The following is a description of a gene set: studied in species Mus musculus Mouse Gene Set: GOBP_PROTEIN_TRANSPORT The directed movement of proteins into, out of or within a cell, or between cells, by means of some agent such as a transporter or pore., and this is the list of marker genes: Stx1a, Cplx1, Chmp6, Pom121l2, Grb2, Clstn3, Igtp, Hspa9, Os9, Gabarap, Ptpn14, Dgkd, Prkcz, Tmed2, Psap, Timm23, Egfr, Anp32b, Ghsr, Kif1a, Il1b (interleukin 1 beta), Ice1, Nlgn2 (NCBI Gene Id 216856), Ap4b1, Zdhhc17, Ankrd1, Rptor, Htt, Psen1, Washc2, Hsp90b1, Mir130a, Rab32, Ap5b1, Ptpn5, Traf3ip2, Erp29, Tfr2, Camk2n1, Lyst, Nutf2-ps2, Pttg1ip2, Arl6, Kpna6, Ang6, Stk4, Atp13a1, Ykt6, Ube2q1, Arrdc2 (arrestin domain containing 2), Snx21, Vti1b, Selenot, Cd74, Mapk8ip3, Akt1, Ramp1, Dnajc19, Tmem132a, Senp2, Tomm7, Cry2, Rab10, Nr1h4 (NCBI Gene Id 20186), Nup50l, Bcap29, Lin7b (lin-7 homolog B, crumbs cell polarity complex component), Sirt1, Nup42, Angpt1, Clu, Chmp4c, Rab11fip1, Pgrmc1, H2-DMa, Apba3, Rabif, Vps13d (NCBI Gene Id 97180), Snx20, Kcnj11, Pex1, Cd36, Mup4, Calcrl, Cask, Unc93b1 (NCBI Gene Id 54445), Srp54a, Rangap1, Ndp, Map1a, Sytl3, Tek, Stx18, Tmed6, Tomt, Vps37c, Tbc1d17, Tmem97, Fhip1b, Nacad (NCBI Gene Id 319576), Cnih4, Bcs1l, Hspa5, Ipo5, Tecpr2, Adam9, Arf2, Lypla1, Pdcd6ip, Ptpn11, Pttg1ip, Aup1, Dynll1, Arl8a, Neo1, Guk1, Pex10, Ccn3, Atg4a, Ptpmt1, Neurl1b, Gper1, Selenok, Tmem167, Edem1, Vps35, Mpc2, Drd3, Elmod3 (ELMO/CED-12 domain containing 3), Zbed6, Myh10, Jup, Nsg1, Lrrc8a, Hps6, Il12a, Apobec1, Zfand1, Sec23b, Dyrk1a, Zc3h12a, Bcl3, Adcyap1, Washc1, Camk1, Lcp1, Chrm3, Pex16, Irgm2, Ier3ip1, Nkx6-1, Ergic3, Parp11, Cd200, Timm44, Hyal2 (hyaluronoglucosaminidase 2), Stradb, Ffar1, Il6, Nmd3, Gpr39, Atg16l2, Hikeshi, Rab11fip2, Dynlt1c, Picalm, Apoc2l, Stx3, Sirt4, Doc2b, Hm629797, Dmap1, Cav1, Grpel2, Ranbp6, Dennd10, Fras1, Tlr4, Mdm2, Apob, Cmtm6, Cartpt, Spire1, Use1 (NCBI Gene Id 76848), Csk, Cog8, Rab9, Vcp, Vldlr, Rab3c, Pik3r2, Chmp1b2, Golga2, Rab2b (NCBI Gene Id 78858), Wls, Eps15, Bbs2, Il1a, Flna (filamin, alpha), Ffar3, Faf2, Brca1, Cog3, Ect2, Tm9sf4, Rep15, Gosr2, Rfx3, Vps50, Dgat1, Uso1, Kcnq2, Pik3c3, Romo1, Rapgef3, Vps52, Snx25, Trpm4, Ildr2 (immunoglobulin-like domain containing receptor 2), Herpud1, Aacs, Pitpnm1 (phosphatidylinositol transfer protein, membrane-associated 1), Btf3, Timm13 (NCBI Gene Id 52584), Snap23, Trpm2, Nploc4, Fcgr4, Ang, Rab3il1, Mdfic, Foxa2, Synrg, Sort1, Elavl1, Atp6ap1, Ppard, Copz1, Map4k4 (NCBI Gene Id 98646), Hcfc1, Rabgap1l, Ccdc93, Rhbdf2, Exoc6, Uts2 (urotensin 2), Apbb1, Ctdspl2, Prepl, Arf6, Efcab7, Camk2a, Tardbp, Cplx3, Cog1, Fam3a, Ripor1, Fam3b, Exoc1, Cd3g, Myh9, Snx9, Agtr2, Pex7, Rab27a, Pex14, Ddx5, Gopc, Snx7, Snx4, Rbsn, Dmbt1, Pde4c, Tgfb3, Sidt2, Gdi2, Cd38, Lrrk2, Kpna7, Dennd1a, Stat3, Vps37a, Ppm1a, Vps41, Dnajc1, Timm17b, Plekhf2, Marcks (myristoylated alanine rich protein kinase C substrate), Ift56, Ing1, Pkig, Scarb2, Glp1r, Afm, Egr2, Cftr, Kcnq3, Itpr1, Mup5, Srcin1, Phaf1 (NCBI Gene Id 338512), Lamp2, Vps18, Uhmk1, Sorcs2, Anxa7, Stx11 (NCBI Gene Id 74732), Pde8b (NCBI Gene Id 77611), Snx10, Pde1c, Tiam1, Snx30, Efna5, Klhl20, Tomm70a, Vipas39, Slc30a8, Kif20b, Ranbp3, Snord33, Rab7b, Rph3al, Rpain, Kif3a, Ang4, Pick1, Idh2, Casr, B4galnt2, Tomm20, Pex6, Notch1, Arl4d, Ang5, Tlk1, Kpna2, Nup62, Mtx2, Hnrnpm, Fchsd2, Pcsk1, Fga, Aftph, Agtr1a, Sec61a1, Hook2, Stxbp2, Pex19, Nxt1 (NTF2-related export protein 1), Stx17, Gle1, Tfap2b, Prickle1, Prkcq, Nup85, Derl1, Grin2a, Rtn2, Bloc1s6, Kpna4, Arhgef5, Itsn1, Frat1, Bet1l, Bmpr1a, Glul, Chchd4 (NCBI Gene Id 72170), Exoc5, Ankle1, Mtx1, Septin8, Duoxa2, Bbs7, Gpr27, Cltb, Rph3a, Scamp3 (NCBI Gene Id 24045), Heatr3, Ahi1, Stim1, Ppp3cb, Acsl4 (acyl-CoA synthetase long-chain family member 4), Snord34, Rack1, Fndc1, Pdcd5, Cltrn (NCBI Gene Id 80522), Isl1, Mylk, Sergef, Cep131, Rab19, Tom1l1, Ipo4, Prkaca, Gipr, Rilpl1, Zg16, Vps4b, Ankrd27, Stx19, Timm8a2, Rab7, Trim3, Afg2b, Vps36, Ccl5, Rhbdd3, Cog5, Bmpr2, Nup155, Snap91, Cttn, Frmpd1, Nup50, Pgap1, Ap1s2, Rab31, Hnf1b, Vps13c, Rab22a, Pdx1, Rilp, Ap4m1, Ppt1, Hpse, Peg12, Dynlt1a, Six2, Pik3r4, Atg14, Gnaz, Tnpo3, Pex5, Rest, Xbp1, Vamp2, Crhr2, Ramp2, Kpna2rt, Hmgn3, Cd24a, Ehd1, Selenbp2, Gpihbp1, Becn1, Tango2, Ranbp3l, Snx17, Dynlt1b, Nup160, Hadh (NCBI Gene Id 99932), Tram1, Rab5c, Unc119, Stx5a, Eipr1, Plk3, App, C2cd2l (C2 calcium-dependent domain containing 2-like), Snx27 (sorting nexin family member 27), Pkd1, Tmed4, Sec61g, C1qtnf5, Stxbp3, Trarg1, Rims1, Ap1g2, Sacm1l, Osbp, Nolc1, Sel1l, Rftn1, Mup3, Cdkn2a, Pde3b, Raf1, Il33 (NCBI Gene Id 77125), Cbl, Tmed10-ps, Nasp, Cd81, Bcr, Pex26, Mup1, Hdac6, Nup133, Bnip1, Glud1, Abcb9, Apbb3 (amyloid beta precursor protein binding family B member 3), Vps33a, Rab34, Hspb1, Pex2, Rab11fip3, Arl6ip5, Bad, Usp9x, Mc4r, Chmp2a, Capn10, Nfkbia, Chrd, Sec23a, Piwil4, Tnf, Dnlz, Gga1, Tgfbrap1, Rab6b, Golph3l, Rbm4, Fermt1, Dnaja1, Ranbp2, Baiap3 (NCBI Gene Id 545192), Myo5b, Ank2, Arfrp1, Arcn1, Rab15, Plek, Pom121, Arfip2, Rab5a, Seh1l (NCBI Gene Id 72124), Sfrp1, Rapgef4, Ap1g1, Edn1, Snx33 (NCBI Gene Id 235406), Rhbdf1, Mtch2, Cenpf, Snupn, Lrrc7, Sprn, Scrib, Nr1h2, Arhgap1, Lyplal1, M6pr, Spry2, Gzmb, Hsp90ab1, Slc15a3, Myt1, Grpel1, Rab39, Slc51b, Fam53a, Ednra, Umod, Prpf4b, Cdk16, Abca12, Mon1a, Prr5l, Erc1, Arrdc1, Tbc1d13, Mlc1, Frmd4a, Vsnl1, Cfl1, Bcap31, Blzf1, Chm, Vps51, Stx7, Epm2a, Cog7 (component of oligomeric golgi complex 7), Kcnq1, Lrsam1, Ncoa6, Stx1b, Rab2a, Bbs5, Nadk, Mir200a, Vamp3, Tmed7, Arrdc3, Oprm1, Ipo8, Sirt3, Vps13a, Lsr, Scamp2, Clip3, Rp2, Lman2l, Rab43 (NCBI Gene Id 70089), Sec22a, S100a13, Stk3, Cdk5, Lepr, Srpra, Sec62, Fgf9, Ift25, Atg3, Rab6a, Drd2, Snx32, Sco1, Neurl3, Copg1, Tamalin, Xpo6, Ins2 (NCBI Gene Id 16334), Rsad2, Trim28, Snx1, Tsc2, Sft2d1, Inhbb, Malrd1, Epha5, Tap1, Snx3, Appbp2, Arl3, Hap1, Erlec1, Ubap1, Pim3, Lrp1, Scamp5, Exoc8, Chp1 (calcineurin-like EF hand protein 1), Dnajc27, Xpo4, Ube2j1, Olfm2, Tacr2, Gcg, Ap2a1, Steap3, H13, Nup210, Oaz1, Yipf5, Lyset, Zic1, Acd, Adipoq, Chmp4b, Tcf7l2, Rab33b, Timm22, Ywhah, Surf4, Pard6a, Samm50, Lman2, Arrdc4, Cep41, Jak2, Stam2, Myrip, Cbln4, G6pc2, Kif5b, Acvr1c, Vip, Tnks, Bsg, Ccdc22, Atg10, Cetn3, Tomm6, Bicd2, Il13, Agap3, B3gat3 (NCBI Gene Id 72727), Crh, Ipo11, Rfx6, Necap2, Pml, Coro7, Akirin2, Tram2, Snap25, Rhob, Kif3b, Yif1b, Comt, Cdc42, Yod1, Pck2, Prkcd, Chrm1, Lin7c, Gpr68, Ufm1, Fto, Ctns, Tmed10 (transmembrane p24 trafficking protein 10), Tvp23a, Nos3, Sec31a (NCBI Gene Id 69162), Gck, Rab4a, Slc1a1, Ffar2, Il1rn, Bbs9, Pdcd10, Sec61bl, Cd2ap (CD2-associated protein), Rab35, Snap47, Vps35l, Slc4a8, Ift46, Sec24a, Msr1, Cwh43, Tnfrsf1a, Entr1, Rab8a, Prf1, Ifng, Nup58, Trmt10b, Cacna1e, Dennd1b, C1qtnf12, Vps16, Snx13, Tram1l1, Slc2a2, Prkar1a, Tmem30b, Rd3, Gja1, Scg5, Rrbp1, Appl2, Nup43, Birc5, Sybu, Sar1b, Golt1b, Mon2, Rab4b, Arhgap44 (NCBI Gene Id 216831), Ap1m1, Filip1l, Prkce, Rab3ip, Ins1, Clta, Aspscr1, Hnf4a, Rab24, Vps54, Ep300, Chmp1b, Gckr, Idua, Rcn3 (reticulocalbin 3, EF-hand calcium binding domain), Tmem9, Tmem258, Pafah1b1, Camsap3, Hspa4, Adcy5, Agt, Slu7, Sytl1, Negr1, Hmgcr, Trpa1, Hif1a, Syt9, Drd1 (NCBI Gene Id 77537), Rab14, Lep, Nup214, Rinl, F2r (coagulation factor II thrombin receptor, NCBI Gene Id 218465), Nmu, Timm8a1 (NCBI Gene Id 30058), Gm14461 (predicted gene 14461), Apod, Prkn, Midn, Vps28, Cacna1d, Ptprn, Arf4, Gosr1, Sec31b (SEC31 homolog B, COPII coat complex component), Cetn2, Sec63, Preb, Fgg, Ehd3, Fam53b, Zfp384, Serp1, Ift22, Apoc2, Yif1a, Nup88, Abca1, Sec22b (SEC22 homolog B, vesicle trafficking protein), Adcy8, Rbm22, Atg4d, Stx16, C2cd5, Rab13, Myo7a, Nup107 (nucleoporin 107), Cnst, Gpld1, Ift27, Ano1, Arfgef1, Orai1, Ap2s1, Atf2, Ap3s2, Sfn, Kpna3, Pkia, Insig1, Fam91a1, Cep290, Srebf1, Oga, Arl8b, Ptprv (NCBI Gene Id 64447), Dnm1l, Rab9b, Ppp3ca, Ttn, Timm10b, Snx6, Mvb12b (NCBI Gene Id 98948), Ngfr, Madd, Vti1a, Arfgef2, Tbc1d5, Cplane2, Ipo9 (importin 9), Dennd4c, Prkcb, Mcoln2, Dynlt1f, Ift20, Xpo7, Mpdz, Nup54, Optn, Camk4, Kcnj8, Slc15a2, Elmod1, Arrdc5 (arrestin domain containing 5), Actn4, Tomm40, Bglap2, Sil1, Rabgef1, Nup93, Gfer, Zfand6, Pclo, Tvp23b, Ptpn1, Akap1, Rac1, Sox4, Rufy1, Rab26, Ubr5 (ubiquitin protein ligase E3 component n-recognin 5), Ap5s1, Slc16a1, Stx8, Ptpn22, Arrb2, F2, Snapin, Nup98, Exoc6b, Itgb1, Dph3, Gnptab (N-acetylglucosamine-1-phosphate transferase, alpha and beta subunits), Ppid, Slc18a2, Sucnr1, Snx14, Sstr5, Bag3, Nxt2, Plcb1, Tmem30a, Oaz2, Sft2d3, Dnm2, Xpot, Sorl1, Aktip, Vps26a (NCBI Gene Id 30930), Myo18a, Rufy3 (RUN and FYVE domain containing 3), Clstn1, Unc13b, Sar1a, Gcc2, Vps53, Vps29 (VPS29 retromer complex component), Ndfip2, Ppm1f, Stxbp5l (syntaxin binding protein 5-like), Grip2, Gja5, Ptpn23, Clip1, Cd63, Zw10, Rab36, Tgfb1 (NCBI Gene Id 21803), Rab23, Porcn, Casp1, Vhl, Snx11, Mtm1, Ap3m1, Cabp1, Napg (NCBI Gene Id 71953), Scamp1 (secretory carrier membrane protein 1), Ppia, Pola2, Abcg1, Kif5c, Irs2, Selenos, Snx24 (NCBI Gene Id 75707), Lca5, Mapk10, Pla2g6, Fbn1, Pcnt, Chml, Necap1, Abra, Gsdmd, P3h1, Edem2, Rab27b, Ensa, Snx12 (sorting nexin 12), Acvr2b, Wdr11, Gapvd1, Amn, Ipo13, Cchcr1, Rab12, Hmga1, Golga4, Chmp7, Mmp12, Tango6, Ric1, Bmp4, Six3, Tomm20l, Tomm22, Nxf1, Atg7, Ang2, Ap5z1, Gnao1, Rab18 (NCBI Gene Id 19330), Gpr89, Ei24, Sirt7, Adra2a, Ndfip1, Bbs4, Stam, Rab17, Npff, Mavs, Rhbdd1, Snx18, Trim37, Sft2d2, Phax, Slc12a2, Eny2, Trem2, Timm10, F2rl2, Timm29 (translocase of inner mitochondrial membrane 29), Tgfb2, Macir, Lsg1, Cdkn1a, Slc15a4, Cckar, Napa, Vps26c, Lhcgr, Dop1b, Fgb, Svip, Nf1 (neurofibromin 1), Kif5a, Sh3kbp1, Irgm1, Mapk14, Snx2, Tmed5, Slc7a11, Syvn1, Rasl2-9, Slc7a6os, Mamdc4, Wipf1, Ank3, Snx19, Dnajc15, Cacna1c, Apba2, Copb2 (COPI coat complex subunit beta 2), Snx16, Snap29, Nedd4, Hps1, Lmtk2, Arl14, Chmp5, Hook3 (NCBI Gene Id 76095, hook microtubule tethering protein 3), Mlph, Copg2, Wwp2, Gdi1, Zpr1, Drd4, Sec16b, Rab1a, Sys1, Vps26b, Oxct1 (NCBI Gene Id 67041), Nup62cl, Ap2b1, Timm17a, Zfand2b, Ednrb, Ap2a2, Mcfd2, Desi1, Bard1, Arl4c, Neurod1, Rab11b, Praf2, Tm7sf3, Nos2, Slc25a22, Scamp4, Bmp2, Strada, Mmp13, Ap4s1, Copz2, Or51e2, Asph, Cubn, Park7, Xpo5, Grk3, Rab25, Vegfc, Anxa5, Plekhm1, Tlr2, Vps25, Trh, Rbp4, Agap1, Mon1b, Chmp3, Washc4, Stxbp1, Selenbp1, Ap1s1, Phb2, Ranbp17 (RAN binding protein 17), Tbc1d1, Atp2c1, Snord32a, Sytl4, Sec16a, Ktn1, Abcc8, Kcnip3, Hsp90aa1, Vamp5, 5730455P16Rik, Ptprn2, Anxa1, Sh3tc2, Spire2, Laptm5, Timm8b, Krt20, Pcid2, Rab3d, Scfd2, Grip1, Mcu, Nos1, Slc15a5, Timm9, Gga2, Rab11a, Ufd1, Slc9b2, Syndig1, Myo5a, Nup35, Txn1, Mup11, Agk, Ndufa13, Aifm1, Tpr, Kpnb1, Slc15a1, Mttp, Wdr72, Rab11fip5, Calr, Phip (pleckstrin homology domain interacting protein), Jagn1, P2rx7, Snf8, Med1, Vps4a, Rab3b, Copb1, Pex3, Tcirg1, Mtnr1a, Bbs1, Akap5, Astn2, Cadps2 (Ca2+-dependent activator protein for secretion 2), Fuz, Ahctf1, Ap1m2, Timm21, Mapk1, Snx15, Gpr119, Sec61b, Nagpa (NCBI Gene Id 27426), Trim23, Arl11, Adar, Ccdc91, Kcnj6, Sec61a2, Tmco6, Sri, Zmat3, Tesc, Duoxa1, Exoc4, Cyp51, Rab5b, Ap2m1 (adaptor-related protein complex 2, mu 1 subunit), Lman1, Clock, Shh, Lmf1, Spag17, Kpna1 (karyopherin subunit alpha 1), Gna11, E2f3, Myom1, Nr1d1, Sp100, Arfgap1, Ywhab, Nr0b2 (nuclear receptor subfamily 0, group B, member 2), Commd1, Ap3m2, Steep1, Lin7a, Rilpl2, Ap3b1, Gripap1, Large1, Stx12, Lrp5, Cse1l, Smurf1, Smo, Exoc7, Rangrf, Mtnr1b, Scfd1, Agrn, Mia3, Nutf2-ps1, Rabep1, Sdad1, Copa, Ube2g2, Kdelr3, Pex5l, Pik3r1, Gli3, Arl5a, Tmem129, Tomm40l (translocase of outer mitochondrial membrane 40-like), Mcm3ap, Vps37d, Arfip1 (ADP-ribosylation factor interacting protein 1), Hcls1 (NCBI Gene Id 15163), Ehbp1, Rab37, Tmed3, Slc8b1, Arhgap33, Src, Ncoa4, A1cf, Derl3, Sncg, Lmna, Uevld, Gas6, Nfatc3, Srp54c, Golga7, Comp, Tom1, Mir410, Reep2, Ttc8, Tnpo2, Fam3d, Unc119b, Tenm1, Ist1, Vps39, Heatr5b, Ywhae (NCBI Gene Id 22627), Tfrc, Lrp2, Ap3d1, Aagab, Gnas (NCBI Gene Id 78290), Tmed1, Gbp4, Foxo1, Svbp, Vps33b, Pfkl, Gsk3b, Hspd1, Ptger4, Atg16l1, Stxbp5 (NCBI Gene Id 78808), Txnip, Snx5 (NCBI Gene Id 99195), Uaca, Washc3, Arl4a, Atp13a2, Nup188, Lonp2, Cope, Ndufaf2, Gbf1, Il10ra, Pex13, Rint1, Arl5b, Ppp3r1 (NCBI Gene Id 19058), Syt7, Cltc, Per2, Gip, Cln3, Snx31, Arf1, Cpt1a, Cog6 (component of oligomeric golgi complex 6), Exoc2, Myo6, Tmed11 (transmembrane p24 trafficking protein 11), Hcar2, Slc35d3, Cela2a, Hdac3 (histone deacetylase 3), Pex12, Bmal1, Kif20a, Rab21, Nnat, Pcm1, Vta1, Gnai1, Dctn1, Dlg2, Tomm5, Pparg, Myo1d, Nsf, Rabl3, Rab3a, Mafa, Stx2, Pfkm, Dtx3l (deltex 3-like, E3 ubiquitin ligase), Rabl2 (RAB, member RAS oncogene family-like 2), Ap3s1, Psmd9, Atg4c, Gabarapl2, AU015836, Nr1h3, Gfap, Oaz3, Epb41l1, Tsg101, Kdelr1 (KDEL (Lys-Asp-Glu-Leu) endoplasmic reticulum protein retention receptor 1), Zdhhc2, Hnf1a, Sirt6, Derl2, Chmp2b, Spg11, Trip11, Fkbp1b, Ran, Dennd2a, Vamp8, Neto1, Akap8 (NCBI Gene Id 67462), Rab38, Arrb1, Bloc1s3, Mup2, Apba1, Blk, Psen2, Jakmip1, Adora2a (NCBI Gene Id 11540), Pam16, Kcnn4, Ap1s3, Ramp3, Ap3b2, Kif13a (NCBI Gene Id 328239), Tom1l2, Ipo7, Chmp1a (charged multivesicular body protein 1A), Ifnb1, Sec13, Dop1a, Klf7, Aaas, Sytl2, Rab8b, Irs1, Syt4 (synaptotagmin IV), Brsk2, Chp2, Arfgap2, Kif17, Exph5, Eif3e, Napb, Rffl, Syk, Xpo1, Rab39b, Sptbn1, Uqcc2, Gpm6b, Cavin1, Rab28, Mia2, Col1a1, Vps8, Il12b, Vps45 (vacuolar protein sorting 45), Ucp2, Kcnb1, Frat2, Sumo1, Ptbp1, Cdh1, Cadps, Cyb5r4, Tap2, Nup153 (nucleoporin 153), Stx4a, Mlxipl, Dag1, Cnr1, Prkd1, Sec22c, Cbln1, Golt1a, Vps11, Hspa8, Tunar, Dab2 (disabled 2, mitogen-responsive phosphoprotein), Smad2, Trp53, Kif18a, Chga, Apoc3, Exoc3, Arf3, Nutf2, Dnajc14, Emd, Stx6, Timm50, Sqstm1, Snx8, Tmed9, Egf, Ptger3, Ap4e1, Sytl5, Ndel1, 1700009N14Rik, Alox5, Ndc1, Pdcd5-ps, F2rl1, Ghrl, Ccdc186, Bet1, Ap5m1, Gprc6a, Dtnbp1, Vmp1, Rims2, Tnpo1, Ahcyl1, Pdcd6 (NCBI Gene Id 18570), Golph3, Pkdcc, Stxbp4, Ifi27, Adtrp, Apoe, Snord35a (NCBI Gene Id 27211), Gorasp1, Appl1, Acsl3, Abat (NCBI Gene Id 57428), Gga3, Cog4, Nr4a1, Pfkfb2, Igf1, Arfgap3, Ptgs2, Rap1gds1, Arf5, Myo1b, Fam76b, Rab20, Trpc1, Fmn2, Mvb12a, Hook1, Atg4b, Arl1, Slc10a7, Kdelr2, Krt18, Rab1b, Ucn3, Zfyve16, Vgf, Washc5, B3glct, Fkrp, Cdk1, Fam53c, Trpm5, C1qtnf3, Eif4enif1, Arl5c, Klc1, Micall1, Nup37, Macf1, Mtch1, Rab29, Gnaq, Rabep2, Ubac2, Vamp4, Hgs, Tuba1a (NCBI Gene Id 22142), Ap1b1, Vps37b, Cog2